The following is a description of a gene set: The process in which the developmental fate of a cell becomes restricted such that it will develop into an epithelial cell. species: Mus musculus Mouse Gene Set: GOBP_EPITHELIAL_CELL_FATE_COMMITMENT, and this is the list of marker genes: Neurod1, Spdef, Nkx2-2, Fgfr3, Mir450b, Chrd, Flvcr2, Sostdc1, Pdpn, Rbpj, Rara, Nr2f2 (NCBI Gene Id 67192), Hoxa13, Arx, Gata4, Dll1, Notch1, Acvr1, Prox1